Given this list of marker genes VPS13A, FTL, GCDH, RANBP2, TUBB3, here is a description of the gene set: Any structural anomaly of the putamen, a brain nucleus which together with the caudate nucleus and fundus striati makes up the striatum. Human Gene Set: HP_ABNORMAL_PUTAMEN_MORPHOLOGY Abnormal putamen morphology species: Homo sapiens